The following is a description of a gene set: Human Gene Set: GOMF_G_PROTEIN_COUPLED_OPIOID_RECEPTOR_ACTIVITY Combining with an opioid (any narcotic derived from or resembling opium), and transmitting the signal across the membrane by activating an associated G-protein. studied in species Homo sapiens, and this is the list of marker genes: NPBWR1, OPRD1, OPRL1, OPRM1, OPRK1, NPBWR2, SIGMAR1